The following is a description of a gene set: Human Gene Set: ZBTB12_TARGET_GENES from publication Yevshin I, Sharipov R, Kolmykov S, Kondrakhin Y, Kolpakov F (PMID 30445619) species: Homo sapiens Genes containing one or more binding sites for (ZBTB12) in their promoter regions (TSS -1000,+100 bp) as identified by GTRD version 20.06 ChIP-seq harmonization., and this is the list of marker genes: PPIP5K2, PPP6R1, VIRMA, PPT2-EGFL8, FBXO24, BLOC1S1 (biogenesis of lysosomal organelles complex 1 subunit 1), PTMA, ZNF76, FABP5P3, BIVM, NOL11, LRRC41, ARMH4, TRIM41, ITPK1, CIC, RAB6A, CTDSP2, DYNLL1, DCTN4, TXNL4B, IL4I1, ABCA15P, CLCN3, LEMD3, PTGES3L-AARSD1, PTMS, ABHD3, TCP1, SLBP, PADI1, DPH2, BRF1, SLC25A42, SNAP47, FOSB, VTRNA1-2, ABHD13, MATCAP2 (NCBI Gene Id 23366), NICOL1, PHB1, ANO6, MARCHF6, AP3B2, ATP6V0B, RRS1-DT, PHLPP1, EIF5A, MACO1, AGFG2, TMEM116, NDUFS8, ISLR2, NUDCD1, FKBP3, RBM10, ATP6V1E1, ORAI1, TCF3, MSI2 (NCBI Gene Id 124540), CCNO-DT, ARFGAP2, ANO8, FBLN1, LTBP4, ARMC7 (NCBI Gene Id 79637), RSPH1, ZFAND4, MYH9-DT, APBB3, RBM17, DCP1A, C4orf46P2, MYPN, PTER, TMEM219, PRRT3-AS1 (NCBI Gene Id 100874032), CRLF3, TRIM35, RPS12, ZNF687, ILDR2, MTF2, L3MBTL2, RASSF1-AS1, DIS3, PLEKHG2, RIBC1, HSPA2-AS1, CSE1L, TUFT1, EFNA4-EFNA3, FLOT1, HEXA-AS1, HPGD, FANCC, TOR1AIP1, DBP, ZNF518A, ADPRM, HS3ST3A1, RER1, ZNF776, SMAP1, MTCO3P12, ZNF286A, NDUFA3, AP3S2 (adaptor related protein complex 3 subunit sigma 2), ZNFX1, NAA80, BRWD1, KPNB1-DT, PAFAH1B3, HSPE1, ZNF217, FDFT1, NCKIPSD, UBAC1, SLC35F1, HNRNPH2, FMNL2, SEPTIN3, HSPD1, HOXA4, USP17L23, SNORD12C, MFSD5, EIF4A2, IDH3B, MRNIP, TSEN15, SLC1A4, RAI14, CCNE1, RRM1, ANKRD49, PTK2, PGF, MRPS18B, NOLC1, MEAK7, GATAD2B, KMT2B, BARHL2, SYPL2, ZC3H10, SLC30A6, LGALS1, CAPS2, SNX10-AS1, ASPH, SAMD4B, TPGS1, HUWE1, CREB3, FCHO2, LINC00680, LIG3, APPBP2-DT, CNPY4 (NCBI Gene Id 245812), HOXC6, PGM2L1, CHEK2, LAMA4, ZNF566-AS1, DUSP6, ZNF609, NFATC4, STX16, RFTN1, RSPH4A, GPATCH3, SERTAD4, CDK1, BCL6, HIF1AN, FAM201A, CERT1, POMGNT2 (NCBI Gene Id 84892), DLGAP5, ZNF283, PTGES3L, LYPD5, SYTL3, COX6B2, ZFP14, METTL17, SLC31A2, ENSG00000250230, CRTC2, BTK, SPHK1 (NCBI Gene Id 8877), TJP3, CAPNS1, IQSEC1, EP300 (NCBI Gene Id 2033), INHCAP, RPS6KA2, HBS1L (HBS1 like translational GTPase), LINC01003, RAB11FIP2, CRTAP, PAPSS1, SAFB, LMO4, TM9SF3, IDS, STAT6, PAPOLA (NCBI Gene Id 84718), RHBDD1, PLEKHG4, AMOTL1, CPSF7, MIR6853, RN7SL774P, ARID4A, B3GALT9, NCAPD3, C11orf68, NME1, ZNF44, EPCIP-AS1, IRF3, USP45, KCTD10, SCAND2P, FAM174C, PEG10, XPC, QTRT1, RPL37A-DT, DCAF8-DT, DALRD3, DZANK1, ZNF717, XIST, LRP11, DDIT4, CEP170, TRAPPC3, SLC4A7, DHPS, SPEN, CCNH, NDUFS7, DHX38, KLHL17, SLC30A6-DT, MMAB, NUDT9, NUP62, C8orf88 (chromosome 8 open reading frame 88), ARID4B, GTF2I, CENPU, RAB11B-AS1, ZNF668, CFAP298-TCP10L, CPSF2, PAXBP1, ARMH3, MTND5P11, DTWD1, C1orf174, TBC1D22A, NEK2, SNAP23, BCL2L13, FUZ, SRRM2, LINC02739, LINC02598, ZC3H7A, RBM15-AS1, CALR, LIG4, CENPT, ZNF343, ITFG2-AS1, JDP2-AS1, RANBP9, NFE2L1, POU2F1, THOC7, NDUFA10, PDCD10, ITPKC, C1orf21 (NCBI Gene Id 81563), LENEP, NCAM1, ACTRT3, RPL39P40, LMNB1-DT, STX10, ZNF513, PELP1, SDCCAG8, RPA2, CBFB, ZNF354B, BRCA1, ZNF546, CDCA4, TEX10, NCLN, RN7SL346P, HMG20A, ATF6, TYK2, NHSL1-AS1, SPANXB1, GSTCD, CXorf58, EGR1, JRK, CWC25, HAUS4, FOXJ3, MIDN, MIR513C, GATAD2A, TTC23, TMEM242-DT, ARRDC1-AS1, SUZ12, HSD17B14, PSMB7, GTF2H4 (general transcription factor IIH subunit 4), P4HB, MIEF2, VPS35L, ENY2, FBXO36 (NCBI Gene Id 130888), NUFIP1, VARS2, MED23, INO80C, TLN1, ARRDC3-AS1, LRRC75B, PTDSS2, JMJD4, CCDC159, FRMD5, USP31, CETN3, MTRF1L, SIPA1L1-AS1, TBX6, BRD10, RPL7L1, RUNDC1, ZNF460-AS1, PSMD11, INCA1, FAM133B, ARRDC3, RBM15, ZNF775, RBM8A, ZFP91-CNTF, FAHD1, GAL3ST4, BATF3, UBE2B, EPRS1 (NCBI Gene Id 2058), ZSCAN23 (NCBI Gene Id 394218), ETV4, JARID2, IRS2, AMDHD2, KMT2C, XPO1, GLI1, DLK2, TECR, CDIP1, NBR1, POLR3F, NUP107, HYAL3, VIM, CHCHD2 (NCBI Gene Id 92547), MYL6B, PSTPIP2, TRMT13, MYCBPAP, ATXN7, NUP88, ULK2, FUT8 (NCBI Gene Id 2530), MIR4716, GPALPP1, ZSWIM6, PPP2R5A, PROCA1, TLCD1, HCFC1R1, DMXL1, LMNB2, BFSP1, CALM1, RCBTB2, CTDSP1, SUCO, RBM27, TRIP12, PRPF38B, APLP1, VLDLR-AS1, SPTLC2, UBE2Q2P1, ZNF736, IGSF9B, OSCAR, CHUK, VPS26B, RHCE (Rh blood group CcEe antigens), MICAL3, ZNF45-AS1 (NCBI Gene Id 118827818), DMRT3, USP39, NAA20, ZNF573, TMEM183A, ENGASE, CHUK-DT, ZNF131, XKR6, ECEL1, SNRPA1 (small nuclear ribonucleoprotein polypeptide A'), FCHSD2, MILIP, RPP40, FRG1HP, NRAV, DMAC2L, MSRA-DT, MTUS1, MRPS18C, TXNRD1, IMPACT, ZBTB12, SPAG4, SELENOF, ZC3H12C, STAG1, FNBP4, TMCO1-AS1, TSPAN31, GLTC1, HEXA, LAMA3, FUT10, PGP, STT3A, MRPL16, ADGRL1, LLPH, SMC3, TRIM68, VIPAS39, ELF1, NKIRAS2, NADK2, WDR36, APBB2, CHCHD2P1, EMP3 (epithelial membrane protein 3 (MAM blood group)), TTC21B (tetratricopeptide repeat domain 21B), RO60, RHBDD3, EIPR1, NAXE, CDH24, INKA2, NBEAL1, DNAJC13, MAP3K7, WDR12, CCDC18-AS1, TOB1-AS1 (TOB1 antisense RNA 1), STEEP1, NHSL3, INTS12, CDK11A, ACTA2, TAB2, UQCRH, ERF, ATXN2, MRPS31, PPP1R12A, GJC2, AGO1, RAB11A, TMCO1, SPC24, DLAT, PALM2AKAP2, KDM1A, TTC13, SMARCD2, EHMT1, MIR6515, MYO5C, ADNP, TMEM205, LIM2-AS1, MSRA, SNRPA1-DT, TEX22, TET1, CCT6B, RPL30P11, OGG1, PRP4K, ARV1, PELP1-DT, ZFTRAF1, SDHC, HOXA-AS3, LRRC28, TBCC, BICRAL, PACS1, NDUFB9, ZNF862, ALG13, PPME1, NOC4L, ZBTB8B, UFM1, GALK2, NDUFS3, PDE4D, KBTBD6, ZNF563, ST6GALNAC2, SUPT16H, SIPA1L3, PXMP4, SLC33A1, ELOVL5 (NCBI Gene Id 60481), DMAP1, SRSF4, RRS1, PLS1, JARID2-AS1, MIPEP, CFLAR, PAK2, CNOT8, SMG8, TMEM147-AS1, R3HDM1, TSHZ3, ENSG00000275740, HSCB, AXL, FAM174B, REPIN1, FOXL1, ANKRD18A, KIF1C, WRAP53, DRG2 (developmentally regulated GTP binding protein 2), PLXDC1, DIS3L2, RIC8B, SF3A3, VPS39, ATG16L2, LINC00667, PRRT1, SMARCAL1-AS1, SLC3A2, FAM228B, ACAT1, EFNA4, HOXB3, PARS2, GMCL1, TFAM, VPS72, PPP1R10, CHASERR, TXNDC9, SLC29A2, CPEB4, TBC1D22A-DT, CCBE1, ZNF404, NKRF, EML2, CA11, UBE2S, NPHS1, GPR4, EPHX2, COPB1 (NCBI Gene Id 51664), CYP20A1, ZMYM6, MGAT1, DACT3-AS1 (NCBI Gene Id 100506068), RTCA-AS1, POLR1HASP, MAPKAPK3, PTK2B, MON1A, BOD1L1, RPL37, ZSWIM5, LLPH-DT, C10orf67-AS1 (C10orf67 antisense RNA 1), SP4, MIB1, LEPR, ASCC1, ZNF383, TMEM9 (transmembrane protein 9), IMPDH1, RAB3D, GRIPAP1, C1orf56, CLTC (clathrin heavy chain), STAG1-DT, MVK, MIR4727, SPPL3, MIA2, IFT81, EIF4G1, RNF43, MCF2L, PAM16, TOMM34, ADRA1A, FRMD4B, ELP6, SLCO5A1, SOD1-DT, ECE1, TRDMT1, PSMB3, STAT2, BRPF1, COQ8A, TWSG1, NRBP2 (nuclear receptor binding protein 2), SLC2A4RG, RAB11B, UBE2Z, FAM230G, CFAP298, HMGN3, PSMA3-AS1, PLCD3, RPAIN, NEK8, BBS2, TBX18, HMGN4, GALNT3, LINC01596, ZFP91, SAMD8, CBX1, PICK1, FBN2, DCAF1, CUL3, ANGEL2, FAM76B, DOLPP1, ST13, ZFP90, MYH9, LCEP2, RNF213-AS1, NPAS3, DNAJC11 (NCBI Gene Id 55735), TOPBP1, AKIRIN2, PPM1B, EFCAB6-DT, THA1P, SCO1, BTN2A1, CCNG2, PRICKLE1, GPX1 (glutathione peroxidase 1), RASSF1, CHCHD1, CDKN2AIPNL, MEF2A, CEP41, TLX1, FAM117A, CCDC121, PRKCZ, NAIF1, SPG21, CCDC8, ENSG00000232876, RRP9, ZFYVE16 (NCBI Gene Id 9765), PCM1, FBXW8, LMNB1, RTTN, ENSG00000267058, WNT5B (Wnt family member 5B), GCFC2, KBTBD6-DT, MSMO1, STARD3NL, CCT3, ZMAT2, RAB10, PRKCZ-DT, SLC24A1, ZNF226, TYMS, SASS6, GPS2, RARS1, LDAF1 (lipid droplet assembly factor 1), DYM, PFN4, CUEDC1, B4GALT6, URGCP, LINC02960, NDUFB1, ZNF768, ZNF646, HNRNPUL1, ZMYND15, NFKBIZ, ZFYVE19, TTC23L-AS1, PRKCSH, NUP155, TEDC1, ZNF879, STX18, FAHD2CP, ERP29, TBC1D9, CDKL3, LEPROT, TBC1D17, AP3B1, ZNF782, CLUH, MIR5091, PGK1, C12orf76, AGBL5, PPP4C, KIFC2, PC, PLD4, MCOLN1, ATP1B2, TOB1, LHX9, PPFIA3, METTL9, DGAT2 (diacylglycerol O-acyltransferase 2), RNF170 (ring finger protein 170), CASC2, SNHG11, ZNF227, ARID1A, RPS7, FADS2, EIF5B, PIGL, HSDL2, KLHDC9, DDX17, LINC00472, ZNF286A-TBC1D26, CAMKMT, TM9SF2, HSPA2, ZNF815P, GCHFR, LRRC51, MADD, POGLUT2, FCHO2-DT (NCBI Gene Id 118597832), BAZ2A, ARL6IP5, PREPL, TATDN1, ZRANB3, ALDH16A1, MTFR2P2, BCAS3, MIR1289-1, CTU1, GSTA4, CCNL1, ATP6V1C1, DEDD2, CDC42SE1 (NCBI Gene Id 56882), AHCTF1, ZNF48, VAV3, MIR4519, COMMD1, ENPP3, NLRP1, CEP120, SYNGR2, PHTF2, XRCC6, AP4E1, MIR762HG, GPD2, IER3-AS1, TBCB, NHSL2, LINC00963, OGA, HOXB13, HINT2, ZNF3, TSACC, MALAT1, TUBB4B, STRN3, ITGB3BP, ROBO3, COMMD2, PKN1, KIF23-AS1, ZNF441, TGIF1, FZR1, PARP1, PI4KB, DHRS4-AS1, STOML1, DCTN1, FAM200C, ULK4, KLHDC3, DUSP22, TRABD2A, NUMA1, COMMD9 (NCBI Gene Id 399879), NME1-NME2, HELQ, SLCO5A1-AS1, NUP54, EMP2, CHRM1, ENSG00000255647, SMARCAL1, CAV1, RASD2, CDC26, ZNF197, ODAD3, NDUFAB1, SRRM2-AS1, CGRRF1, FBXW11 (NCBI Gene Id 23291), AP2B1, RNF227, FAM221A, ATP2A2 (ATPase sarcoplasmic/endoplasmic reticulum Ca2+ transporting 2), PLK4, HCN3, RSPH1-DT, ZC3HAV1, PIP4P1, SMAD6, GGPS1, PRICKLE2-AS3, HNRNPA0, PKN2, PABIR2, CCDC117, XPNPEP3, HSP90AA1, NOC2L, MAGOH-DT, KRT8, GPSM3 (G protein signaling modulator 3), TRAPPC12, EPHA7, FAM118A, WDR11, SPNS1, JDP2, ZSCAN26, LRRC20, BYSL, TBPL1, MACF1, ENSG00000247416 (novel transcript, antisense to NCAM1), KPNB1, PLAUR, PTBP2, ZNF468, TMEM94 (NCBI Gene Id 9772), HEATR5A, RNU12, CLDN23, SOX13, NABP2, MAFF, MN1, ZNRD2, NFIB, GIN1, PRKCH, LINC02846, DMC1, DNAJC17, TAOK2, TROAP, MIA2-AS1, SLFN5, C19orf73, HMGB2, ATP2B4, GOLM2, SLC35A4, YKT6, SLC27A6, MARCKSL1P2, ATXN7L1, ARPC5, EVA1C, C2CD3, ZNF140, NUP133-DT, RTCA, APMAP, GLIPR1L2, GSE1, ZNF436-AS1, C1orf131, RBCK1, POU2F1-DT, ABR (ABR activator of RhoGEF and GTPase), KIF11, STX18-AS1, TRPC1 (NCBI Gene Id 7220), MXI1, IER2, PRR14, NFKBIL1, TRIO, MORC4, SESN3 (sestrin 3), MED24, ZNF780A, STX16-NPEPL1, ATP11C, APPBP2, SF3B4, PBX3-DT, IPO13, MYO5B, IPO8, CEP95, STAT3, HEBP2, NDUFAF3, DUS4L, USP3, LINC00240, NTAN1, NHS, PLA2G6, ZCCHC4, HSPE1-MOB4, EIF5, ZNF28, PNKP, FAM227B, NELFA, EWSR1, SNHG7, PPP6R3, CCT5, NOP16 (NOP16 nucleolar protein), MED25, AHSA1, CEP57, PIBF1, JUND, ZBTB26, MEA1, ATR, PDCD7, ZNF554, TRMU, ACTR2, UBAP2L, WAS, DEGS1, EFCAB6, RPL37A, DMXL1-DT, SOD1, ZNF687-AS1, ENSG00000273145, ATP6V1G2, PDE4DIP, YAP1, DNAJB4, NBR2, ERC2, JADE1, STIP1, BBLNP2, INTS14, RSRC1, NXF1, LIPE-AS1, RBM3, UBXN8, SMC1A, C10orf67, NUP133, FANK1, IFT27, POLDIP3, PSMA4, ESYT1, IDH3B-DT, WDR20, ARHGEF12, KCNIP2-AS1, MKNK2, SESN1, VIRMA-DT, TMPO, GLB1L3, DAP-DT, AAAS, TMEM255A, TTC23L, ATP11A, TUFM, PIH1D1, NEK2-DT, HNRNPA1, CHCHD5, CFAP20, EPHB4, C1orf21-DT, PTCH2, C6orf62, NUS1, CLASP2, UTP25, ASB11, DGAT2-DT, MFN2, MBLAC2, PGM1, ATAD2, CCNO, CUEDC2, HAGH (NCBI Gene Id 3029), PARP3, DACT3, TOP3B (DNA topoisomerase III beta), CFAP418-AS1, SLC25A25, RCOR1, GNPAT, ZIC5, GATA3, KIF17 (NCBI Gene Id 57576), KAT7, MAFG, MIR4999, PRKD2, COMMD3, POLR1H, PLEKHA8P1, PCID2, STX6, ZBTB14, FAM24B, GAS8, POLR3G, ITGA7, MRNIP-DT, MYBL1, GNAI2, RSPH3, LINC01775, WDR87 (WD repeat domain 87), NUP107-DT, PRPF4, LRFN3, TARS2, INKA2-AS1, KANK1, RECQL5, YIF1B, APOO, BCL9, CLGN, GRHL3-AS1 (NCBI Gene Id 105376871), MRPS26, GRHL3, GDF5, AKT2, PSCA, LINC00933, MIR548AL, JAK1, CLN3, CDC42EP4, FBXW2, SLC1A3, DNAJB12, DNAJB6, PIM2, AURKAIP1, ZNF558, ZNF566 (NCBI Gene Id 84924), EIF2B5, KIF23, SNCAIP, LAMA4-AS1, LONRF1, ENSG00000257746, NPC1, GBA2, C10orf88B, GNB2, B3GALNT2, ZNF282, FER, SLC25A4, BAX, DRAP1, TP53, CARD8, THOC6, UBC, NIPSNAP1, SLC25A17, MED20, CLSTN1, ARID5B, MORN1 (NCBI Gene Id 79906), SERPINI1, ZNRD2-DT, C10orf95-AS1, DYNLRB1, TPMT, DKKL1, DDX51, CORO6, TSC22D1, CDKN1B, COQ8B, POLK, MDK, ASF1B, DST, C1GALT1C1, MAP7D1, GTPBP3, LPXN, GUCY1A1 (NCBI Gene Id 2982), PTPN14, PPT2, GINS1, FBXW7, DDX5, LAMP1, SAFB2, MAGOH, DYNC2I2, PTPN1, DCAF7, GPN1, RBM42, ILF2, GIPC1, SORBS2, S100A2, RPL36A-HNRNPH2, LNCRNA-IUR, CCND2, SLC9A1, STIM1, LINC02918, RPL29, C22orf46P, AKT1S1, DNAJB1 (NCBI Gene Id 3337), PAPOLA-DT, AKNA, ATF5, OSBPL1A, CEP250, CDHR2, ZNF585B, LINC01431, SETD6, ABHD12, C15orf40, SLC27A1, ESD, HNRNPAB, ZFAS1, CENPA, ATP7A, MEIS1, MAPK4, ABCF3, SDHAF2, COG2, UBE3B, DPF3, TAF11, PAM, YTHDF2, WDR11-DT, TAF6, VPS33A, KANSL1L, FEM1A, FANK1-AS1, RPL36A, FANCM, ENSG00000239137, EFCAB7, RN7SKP114, MAP4, MRPL4, ZNF436, SAP30BP, CDHR4, SLC19A2, FAF1, WDR62, VTA1, MRPL1, ZNF165, KAT6B, INAFM1, SKIL, WIZ, NUTF2, ZNF603P, SORT1, ANXA2R-OT1, CRNDE, CHEK1, RPS11, ZNF337, ULK3, DCLRE1C, MEF2C, BCL2L12, MRPS10 (NCBI Gene Id 95834), MIR615, CLK4, LSM14A, GBA1, KBTBD4, TMEM147, ALKBH3-AS1, VWA3B, CUL4A, TMEM242, EIF4A1, ZNF823, CDNF, RPL23A (ribosomal protein L23a), LIX1L-AS1, OLA1, MORC3, ENDOV, SFXN5, SART3, STK40, FAM86HP, ZNF280B, HSPA6, DNAAF3, SUZ12P1, HOXD11, UBAP2, ANO10, ACVR1, SGF29, ZNF460, GINS3, RNU6-1228P, PAX3, GLA, TESMIN, RIMKLB, MCTP1, ZNF443, PDXK, PLCH1